Given this list of marker genes Lamb1, Myf6, Lamb2, Prkd1, Nek5, Gsk3b, Mesp1, Sirt1, Bcl2, Mef2c, Rbm24, Ep300, Mamstr, Camk1, Eif5a, Fdps, Atp11a, Mapk14, Lama1, Tshz3, Bmp4, Nrg1, Myog, Tgfb1, Tarbp2, Pin1, Maml1, Efemp2, Myf5, Parp2, Morf4l2, Wnt3a, Hamp2, Neu2, Kit, Pin1rt1, Arrb2, Notch2, Mtor, Mmp14, Bmp10, Cyp26b1, Cav3, Epc1, Igf1, Edn1, Mdm2, Lamc1, Akap6, Smarcd3, Myod1, Smyd1, Actn3, Hopx, Prox1, Sod2, Csrp3, Slc25a4, Tmsb4x, Shh (NCBI Gene Id 20423), Gper1, Efnb2, Notch4, Ddx39b (NCBI Gene Id 68389), Trip10, Myocd, Shox2, Lama2, Piezo1, Hamp (hepcidin antimicrobial peptide), Nid1, Nr3c1, Lmod3, Olfm2, Pias1, Ccn4, Kat2a, Tbx1, Cth, Rbm4, Setd3, Trim32, Mylk3, Notch1, Eng, Adrb1, here is a description of the gene set: species: Mus musculus Mouse Gene Set: GOBP_POSITIVE_REGULATION_OF_MUSCLE_CELL_DIFFERENTIATION Any process that activates or increases the frequency, rate or extent of muscle cell differentiation.